The following is a description of a gene set: Genes predicted to be targets of miRBase v22 microRNA mmu_miR_12186_5p in miRDB v6.0 with MirTarget v4 prediction scores > 80 (high confidence targets). from publication Chen Y, Wang X (PMID 31504780) Mouse Gene Set: MIR_12186_5P species: Mus musculus, and this is the list of marker genes: Dele1, Arid3c, Lhx6, Sprr1a, Clec2e, Elk1, Trim60, Mrpl15, Ctsq, Dcaf7, Rnf150 (NCBI Gene Id 77483), Chd6, Abhd2, Gmnc, Plagl2, Pak6, Rspo2, Clec2g, Slc24a2, Lrcol1, Nova1, Cd5, Sowahc, Gprasp2, Gdap1l1, Ccdc47, Sema4f, Zfp820, 4933402D24Rik, Grap2, Nptx1, Prdm6, Glb1l, Cd53, Ube2z, Clock, Trmt12, Nfic, Cd209g, Casr, Sgk2, Sidt2, Prdm16, Tut7, Nos3, Dock5, Clip3